Given this list of marker genes PIM1, KIF23, KLF2, KLRG1, PCNA, CKS2, TOB1, IL18RAP, S1PR4, GZMA, TXK, DTX1, ITGB7, H2AZ1, MYB, CCL15, GABPB1, TCF7, RASA3, RELB, NFKBIA, PDLIM1, SGK1, STAT5B, CD7, KLF3, NFKBIB, TGIF1, GZMB, here is a description of the gene set: Human Gene Set: MARSHALL_VIRAL_INFECTION_RESPONSE_DN The restriction of influenza A virus replication to mouse respiratory epithelium means that this host response is anatomically compartmentalized, on the one hand, to sites of T cell stimulation and proliferation in the secondary lymphoid tissue and, on the other hand, to the site of effector T cell function and pathology in the pneumonic lung. Thus, it is hardly surprising that virus-specific CD8(+) T cells recovered by bronchoalveolar lavage (BAL) from the infected respiratory tract seem more activated in terms of both cytolytic activity and cytokine production than those cells isolated from the spleen. The present analysis uses Affymetrix microarray technology to compare profiles of gene expression in these two lineage-related, yet anatomically separate, lymphocyte populations. Ninety differentially expressed genes were identified for influenza-specific CD8(+)D(b)NP(366)(+) T cells obtained directly ex vivo by BAL or spleen disruption, with nine genes being further analyzed by quantitative, real-time PCR at the population level. Integrin alphaE, for example, was shown by Affymetrix and real-time mRNA analyses and then by single-cell PCR and protein staining to be present at a much higher prevalence on the BAL CD8(+)D(b)NP(366)(+) set. The unpredicted finding, however, was that mRNA expression for 75% of the genes was lower in T cells from the BAL than from the spleen. Apparently, the localization of virus-specific CD8(+) T cells to the site of virus-induced pathology is associated with a narrowing, or focusing, of gene expression that favors enhanced effector function in the damaged, high-antigen load environment of the pneumonic lung. Genes down-regulated in the influenza-specific CD8+ T lymphocytes from bronchoalveolar lavage (BAL) compared to those from spleen. studied in species Mus musculus from publication Marshall DR, Olivas E, Andreansky S, La Gruta NL, Neale GA, Gutierrez A, Wichlan DG, Wingo S, Cheng C, Doherty PC, Turner SJ (PMID 15831586)